The following is a description of a gene set: Mouse Gene Set: MIR_1258_5P species: Mus musculus from publication Chen Y, Wang X (PMID 31504780) Genes predicted to be targets of miRBase v22 microRNA mmu_miR_1258_5p in miRDB v6.0 with MirTarget v4 prediction scores > 80 (high confidence targets)., and this is the list of marker genes: Cdc42se2, Glis2, Tbc1d13, Dhfr, Nr2c2, Slc7a11, Cyth1, Ptpn14, Sema4c, Xkr8, Fam98a, Ifnlr1, Cab39, Sfxn5, Cxcr3, Ky, Fbxl7, Lin9, Kdm5b, Ccdc184, Arid5a, Wfdc1, Layn, Thbd, Zfp964, Fgf14, Car12, Edem3, Igf2bp2, Kcnip4, Exo1, Trim16, Snx27, Rab2a, Gfm2, Syt14, Golim4, Traf3 (TNF receptor-associated factor 3), Garre1 (granule associated Rac and RHOG effector 1), Mpi, Esrp2, Bltp3a, Syn3, Plbd2, Arnt2, Tmem138, Tacc1, Prrg4, Gtpbp10, Arhgef10, Nckap5l, Ptpru, Rapgef6, Atpaf1 (ATP synthase mitochondrial F1 complex assembly factor 1), Glcci1, Krtap3-1, Grip2, Snx4, Vash2, Rcc1l, Smad7, Calu, Hapln2, Pcyt1b, Angptl2 (angiopoietin-like 2), Becn2, Pou2f1, Scara5, Usp3 (NCBI Gene Id 235441), Polr1e (NCBI Gene Id 64424), Akr1e1, Limk2, Ccdc6, Gas7, Nup214, Rnf168, Tead4, Mier1, Eif3j2, Dip2a, Opcml, Epha6, Pdik1l, Zdhhc1 (zinc finger, DHHC domain containing 1), Nme3, Riiad1, Mecp2, Strn, Sprn (NCBI Gene Id 212518), Tmem231, Exoc3l4, Tktl2, Fbxo3, AI429214, Sh2d2a, Hnrnph2, Synj1, Creb3l1, Slc23a4, Vezf1